The following is a description of a gene set: The process of negative regulation of cell adhesion that results in a cell or sheet of cells splitting off from an existing epithelial sheet. species: Homo sapiens Human Gene Set: GOBP_DELAMINATION, and this is the list of marker genes: ABCA12, SPI1, YTHDF2, METTL3, SPECC1L, AKNA, TRPV4, CDSN